Given this list of marker genes PRKCD, ADCY5, ADCY1, GNA11, CALM1 (calmodulin 1), ADCY4, GNAI1, GNAL, PRKAR1B, ITPR1, GNA14, PLCB1, KPNA2, CAMK2B, PRKCG, PRKAR2A, CAMK2D, ADCY3, GNA15, GRK2, ADCY8, ITPR2, PLCB2, CAMKK1, PLCB4, GNAI2, PRKAR1A, GNAI3, PDE1B, ADCY9, GNAQ, ADCY6, PLA2G4A, CAMK4, CREB1, PDE1C, AHCYL1, PRKCA, ITPR3, PLCB3, GNAT3, PRKAR2B (NCBI Gene Id 5577), NBEA, CAMK2G, PDE1A, CAMK2A, PRKACG, PRKACA, CAMKK2, PRKACB, ADCY2, PRKX, ADCY7, MAPK1, here is a description of the gene set: G-protein mediated events studied in species Homo sapiens Human Gene Set: REACTOME_G_PROTEIN_MEDIATED_EVENTS